Given this list of marker genes HMCN1, PHLDB2 (NCBI Gene Id 90102), FSHR, POMT2, RIC8A, CAV2, PRICKLE1, LAMC1, PHLDB1, COL3A1, CMA1, LAMA1, GAS2, LAMB2, NTN4, CLASP2, FERMT1, EXT1, PXDN (NCBI Gene Id 7837), CLASP1, DAG1, HPN, NID1, COL4A1, POMGNT1, FKRP, LAMB1, RAMP2, CTSS (NCBI Gene Id 50653), LARGE1, PLOD3, NID2, CAV1, LAMA2, COL6A1, FLRT2, FKTN, ITGB1, SPINT2, MMP11, here is a description of the gene set: A process that is carried out at the cellular level which results in the assembly, arrangement of constituent parts, or disassembly of the basement membrane. Human Gene Set: GOBP_BASEMENT_MEMBRANE_ORGANIZATION studied in species Homo sapiens